The following is a description of a gene set: species: Mus musculus Genes containing one or more binding sites for (Thap4) in their promoter regions (TSS -1000,+100 bp) as identified by GTRD version 20.06 ChIP-seq harmonization. from publication Yevshin I, Sharipov R, Kolmykov S, Kondrakhin Y, Kolpakov F (PMID 30445619) Mouse Gene Set: THAP4_TARGET_GENES, and this is the list of marker genes: Knstrn, Zfp672, Sh3bp5l, Ptrhd1, BC051226, Irgq, Cenpo, Daxx